Given this list of marker genes MATN3, PPP1R10, FLRT2, ATN1, PRKCE, CLASP1, TMEM47, WAPL (WAPL cohesin release factor), SYT7, BRD1, SLC35A3, FGF7, ARHGEF12, MAN1A1, RAB11FIP2, COLEC12, JAG1, LDLRAD2, MMP16, DAB2IP, PCDHA5, RNF152, LIN9, RAD51B, ERLIN2, JPH1, POU4F1, ZMPSTE24, HMGB1, EYA1, GRM8, THRB, DACH1, TMX1, ADGRF5, ADCYAP1, RUNX1T1, RASAL2, HOXB2, PLEKHB2, PLAG1, SYAP1, METTL17, GPBP1, ARGLU1, ZFHX4, PNN, GPBP1L1, AKNA, ZC3H12B, TSC22D4, BLTP3B, VEGFA, NTRK2, ING3, RFX4, AFF2, DBR1, DYRK2, ERBIN, KAT2B, BZW1, PRDM8, FNDC3A, PCDHA4, LRRC3B, HDAC4, TMEM266, LRCH2, FGF7P6, CDK19, MAT2B, FGF7P3, OGT, USP3, TRIL, ZC3H7B, MPC1, INPP5D, TMED2, FOXN3, COBLL1 (cordon-bleu WH2 repeat protein like 1), NDUFAF3, CHUK, ZIC4, KLF12, AXIN1, VAPA, BCL2L2, USP15, TSHZ1, KPNA4, BHLHE41 (NCBI Gene Id 79365), GMPPB, TAOK1, CEPT1, PPP6R3 (NCBI Gene Id 55291), NEUROG2, RNF138, HMGXB4 (NCBI Gene Id 96789), SPAG9, SLC4A10 (solute carrier family 4 member 10), TGFBI, NPAS2, TMED7, PTPN12, DVL3, SKIDA1, ZIC1, TFEC, TMEM135, COL1A1, ZNF354C, UPP2, NR5A2, ACTR1B, XPR1, PCDHA7, ATP6V1A, ARF6, PCDHA3 (protocadherin alpha 3), ZFC3H1, ERG, SLC49A4, TRIM8, SRRM1, FGFRL1, MIA2, PHLPP1 (PH domain and leucine rich repeat protein phosphatase 1), MAFB, AP3B1, PNRC1, DENND6A, PCDHA6, AHCTF1, CDCA7, LRRC42, PURB, PCDHA11, EIF4A2, TBC1D15, FAM120A, EIF3J, KCND2, CLEC1A, MYEF2, CHD1L, STK24, KCNH2, SEMA6D, TRPS1, ZBTB2, PCDHA12, KIFAP3, HOMEZ, MEF2D, PPP2R5E, AZIN1, LRATD2, GRIK1, ATRN, PPARGC1A, GRIA2, NOVA1, TCF12, PCDHA8, KCNJ5-AS1, HAPSTR1, TSHZ3, PCDHA13, ZNF583, SPAST, SP7, RTN4RL1, MTCH2, FGFR2, MARCHF3, PCDHA10, MID1, SMC4 (structural maintenance of chromosomes 4), DICER1, PCDHAC1, ESRRG, HS3ST3B1, LRP1, RABL3, ARID1A, LPP, HOXB5, NDFIP1, CUL2, HECA, PCDHAC2, ZNF777, STC1, HECW2, ADGRB3, CELF2, DCUN1D3, DCLK2, SRRM4, SCRT1, ALCAM, ERGIC2 (ERGIC and golgi 2), MYT1, GABRA5, PCDHA2 (NCBI Gene Id 56146), PCDHA1, BCL11B, GHR, PCDHA9, ADAM9, PCSK2, MAP3K2, DDR1, PTPN11, ATP2B1, NKD1, AP1G1, NFS1, NUAK1, PDE7B, here is a description of the gene set: Human Gene Set: TAATAAT_MIR126 Genes having at least one occurence of the motif TAATAAT in their 3' untranslated region. The motif represents putative target (that is, seed match) of human mature miRNA hsa-miR-126* (v7.1 miRBase). studied in species Homo sapiens